Given this list of marker genes SLC27A5, SREBF1, GSTM2, IRS2, GSTA1 (NCBI Gene Id 2938), ACACA, MLXIPL, MTTP, FASN, SLCO1B1, IRS1, FOXO1, INS, APOB, PPARGC1B, GSTA2, ABCC3, FOXA1, FOXA2 (forkhead box A2), ABCC2, ABCC4, here is a description of the gene set: FOXA2 pathway studied in species Homo sapiens Human Gene Set: WP_FOXA2_PATHWAY